Given this list of marker genes SLC25A22, TP73, FAHD2B, TRIB1 (NCBI Gene Id 80272), HAPLN1, ADAMTS6, LHFPL4 (LHFPL tetraspan subfamily member 4), FGFR2, ZZZ3, RAPH1, CD24 (CD24 molecule), SQSTM1, ICOS, UBLCP1, VGLL4, CKMT2, SLC1A2, SPOCK3, RNF141, NKX2-1, SMARCD2, VPS53, ADGRL2, PANK1, LMO3, B3GNT9, MEF2C, RNF169, TRADD, FOXP4, PLG, ERCC4, RNFT2, CDK14, HERC3, PSMD11, CRNKL1, ATP8B2, YOD1, ADRB2, UBFD1, BFSP2, EMC10, SHISA6, CARM1, HPSE2, TNPO1, RASA1, ADAMTS15, ETS1, FUT3, MYPN, PCNX3, TBL1XR1, CBL, PSAP, FBXO11, NIPSNAP1, KCND1, CDH23, SCARA3, MECP2, FOS, B4GALT3, ZBTB39, CDV3, TRIM33, OSBPL3, RTN4RL1, CRISPLD1, LIN9, LGALSL, KDSR, PATL1, TUBGCP4, RFC3, PTCD3, ARMC5, FGD5, DAGLA (NCBI Gene Id 747), SFMBT1, TSPYL1, HDAC11, VASH1, DOCK1, ATP6V0A2, SLC23A3, GGA3, CAMK2A, MARCHF7, OASL, PPP1R1A, LIF, IFNAR1, ZFAND3, ATF6 (activating transcription factor 6), RSAD2, DEFB125, SCNN1A, SALL1, SLC17A8, PRRC2C (NCBI Gene Id 23215), SLC35D1, SUSD6, GPATCH2L, ZBTB40, MTPN, FGF2, IGF2BP3, AKTIP, PDIK1L, MS4A2, DUSP16, RBP1, CEACAM21, PURA, UBE2Q1, SCD, CAMTA1, BTBD9, SH3PXD2A, SEMA4F, TCTA, ATG3, SEC22C, MARCHF9, JUNB, CH25H, AAK1, ALKBH6, NECTIN4, CYB5B, CAMK2G, STAG2, DYNLT5, LINC02873, GFAP, TRMT11, RIN2, FGFR1, DUSP22, PHF20L1, VAPB, DACH1, ADAR, here is a description of the gene set: species: Homo sapiens Human Gene Set: MIR4530 Genes predicted to be targets of miRBase v22 microRNA hsa-miR-4530 in miRDB v6.0 with MirTarget v4 prediction scores > 80 (high confidence targets). from publication Chen Y, Wang X (PMID 31504780)